Given this list of marker genes Mef2c, Sc5d, Pttg1, Prdx2, 4833420G17Rik, Map1b (NCBI Gene Id 268696), Ighm, Ocel1, 1810037I17Rik, Cpsf2, Rpp14, Phlda1, Ackr1, Bcat2, Zfp68, Kcnj9 (NCBI Gene Id 73478), Myoc, Alad, Pdxdc1, Vps52, Scg5, Ccl21a, Pam, Hjurp, Thumpd1, Col4a1, Pstk (NCBI Gene Id 97429), Acaa1a, Erdr1, Cap1, Aldh7a1, Folh1, Gm33887, Gnb1, Rgs19, Snhg11, Tox4, Tulp3, Mtif2, Bcl2a1a, Snhg6, here is a description of the gene set: Mouse Gene Set: CHESLER_BRAIN_HIGHEST_GENETIC_VARIANCE studied in species Mus musculus from publication Chesler EJ, Lu L, Shou S, Qu Y, Gu J, Wang J, Hsu HC, Mountz JD, Baldwin NE, Langston MA, Threadgill DW, Manly KF, Williams RW (PMID 15711545) Neurologically relevant transcripts with highest variance accounted for by mouse strain (genotype) differences. Patterns of gene expression in the central nervous system are highly variable and heritable. This genetic variation among normal individuals leads to considerable structural, functional and behavioral differences. We devised a general approach to dissect genetic networks systematically across biological scale, from base pairs to behavior, using a reference population of recombinant inbred strains. We profiled gene expression using Affymetrix oligonucleotide arrays in the BXD recombinant inbred strains, for which we have extensive SNP and haplotype data. We integrated a complementary database comprising 25 years of legacy phenotypic data on these strains. Covariance among gene expression and pharmacological and behavioral traits is often highly significant, corroborates known functional relations and is often generated by common quantitative trait loci. We found that a small number of major-effect quantitative trait loci jointly modulated large sets of transcripts and classical neural phenotypes in patterns specific to each tissue. We developed new analytic and graph theoretical approaches to study shared genetic modulation of networks of traits using gene sets involved in neural synapse function as an example. We built these tools into an open web resource called WebQTL that can be used to test a broad array of hypotheses.